The following is a description of a gene set: Human Gene Set: ACEVEDO_LIVER_CANCER_WITH_H3K9ME3_DN species: Homo sapiens from publication Acevedo LG, Bieda M, Green R, Farnham PJ (PMID 18413731) There is widespread interest in efficient characterization of differences between tumor and normal samples. Here, we show an effective methodology for genome-scale characterization of tumors. Using matched normal and tumor samples from liver cancer patients, as well as non-cancer-related normal liver tissue, we first determined changes in gene expression as monitored on RNA expression arrays. We identified several hundred mRNAs that were consistently changed in the tumor samples. To characterize the mechanisms responsible for creation of the tumor-specific transcriptome, we performed chromatin immunoprecipitation on microarray experiments to assay binding of RNA polymerase II, H3me3K27, and H3me3K9 and DNA methylation in 25,000 promoter regions. These experiments identified changes in active and silenced regions of the genome in the tumor cells. Finally, we used a virtual comparative genomic hybridization method to identify copy number alterations in the tumor samples. Through comparison of RNA polymerase II binding, chromatin structure, DNA methylation, and copy number changes, we suggest that the major contributor to creation of the liver tumor transcriptome was changes in gene copy number. Genes whose promoters display lower histone H3 trimethylation mark at K9 (H3K9me3) in hepatocellular carcinoma (HCC) compared to normal liver., and this is the list of marker genes: KIF15, NUSAP1, UTP20, NECAP1, H4C15, DYSF, H4C4, VSX2, HAT1, RALGAPB, H2AC4, TRAPPC9, PTH2, NUP210L, ANKRD36, RAB25, KDM5B, ZNF185, ZNF563 (zinc finger protein 563), SLC28A2, SLC26A8, H2AC16, CDCA2, CEP350, TPM1, H2BC12, ENAM, DGKH, PTPDC1, NSF, MMS22L, C7orf33, H2AC11, ZIC2, H4C14, QTRT2, NCAPG2, ANXA2R, H2AC13, ANXA2R-AS1, TMEM237, H4C1, C4orf33, SLC26A2 (NCBI Gene Id 1836), HOXC11, CFH, UBE2Q2, MTHFD1L, TMEM219, SCG5, H4C6, REXO5, AAGAB, CFHR3, ISL2, CCL28, LINC01551, SQSTM1, CFAP69, VTN, H4C13, MYBL1, ZNF385B, KIF20B, USP39, GFPT1, CEP128, BMX, H4C9, SLC25A12, ZNF30, POLE2, H4C8, H2AC17, CEP112 (NCBI Gene Id 201134), NCF2, SPATS2, HOXA1, H2AC15, H4C11, DRAM1, TOX3, AHCYL2, H2AC14, ZNF134, H2BC15, HMGN4, H4C2, H4C16, CA8, KITLG, BTBD8, ST6GALNAC1, MBTD1, LCT (NCBI Gene Id 3938), H4C12, SLC12A8, HOXA13, CAPNS2, OSBPL1A, TUBB4B, IQUB, PIWIL1, HOXA7, BTBD7, CLUL1, H4C5, H2AC12, PTPN22, SLC24A1, H2BC11, H4C3, VSTM1, BCLAF3, TBC1D31, ZNF613 (NCBI Gene Id 79898), MID1, KLHDC1, H2AC8